Given this list of marker genes CCDC115, CAMLG, GALNT2, PGM1, STT3A, ATP6AP2, ALG3, DPM3, ALG9, B4GALT1 (beta-1,4-galactosyltransferase 1), COG6, GORAB, MPI, SRD5A3, EDEM3, ALG6, TMEM199, DPAGT1, PGM2L1, SLC37A4, COG3, COG7, SSR4 (NCBI Gene Id 6748), DDOST, SLC35A2, MAN1B1, ALG1, GET4, MAGT1, PMM2, ALG8, COG8, SLC39A8, COG1 (component of oligomeric golgi complex 1), MGAT2, ATP6V1A, CAD, ALG11, COG2, DPM1, MPDU1, COG5, ATP6V1E1, STT3B, ATP6AP1, ALG2, DOLK, DPM2, ALG12, ALG13, RFT1 (RFT1 homolog), ATP6V0A2, COG4, here is a description of the gene set: studied in species Homo sapiens Abnormal glycosylation An anomaly of a glycosylation process, i.e., a process involved in the covalent attachment of a glycosyl residue to a substrate molecule. Human Gene Set: HP_ABNORMAL_GLYCOSYLATION